Given this list of marker genes Ubc, Galnt15, Mrgprf, Snx25, Lgals1, Cfap161, Anks1b, Dok2, Lekr1, Sec61a2, Nadk2, Cfp, Podnl1 (NCBI Gene Id 546079), Il15, Birc6, Huwe1 (NCBI Gene Id 97602), Ercc2, Glipr1, Spata9, Stx2, Ttc27, Vps13c, Capn1, Camk2d, Tusc1, Pomgnt1, Cemip, Bnc2, Cd34, S100a4, Tlr12, Ctps2, Sybu, Smim38, Rgs16, Uba7, Zwilch, Cysrt1, Spn, Eef1b2 (NCBI Gene Id 80613), Masp1, Rgmb, Ints11, Cbl, Rps27l, Fbxw2, Tardbp, Klk10, Ube2t, Klhl22, Trmu, Ccr5, Snx17, Ptpn22, Hmgn1, Dock11, Dlgap2, Pih1d1, Cfap69 (NCBI Gene Id 207686), Cyfip1, Fyb2, Adgrg5, Adamtsl4, Sema3a, Ppp1r11, Thbd, Cd300lb, Apbb2, Prkcb, Slc39a12, Fn1, Spag5, Ahrr, Lgals3, Cabp4, Muc19, Pla2g4a, Axl, Cep89, Fah, Firrm, Lrp1, Fxyd5, Lst1, Gzmg, Glrx, Fam20a (NCBI Gene Id 208659), Itgbl1, Zfp740, Cd4, Gtf2h4, Nlrp3 (NCBI Gene Id 216799), Map1a, Calm3, Fastkd2, Pnck, Wnk1, Abca1, Mmp19, Il6st, Drg1, Fus, Dpep3, Ccnd1, Cdc7, Trpm2, Supv3l1, Mmp11, Elk4, Apobr, Strap, Vcl, Pdgfra, Kcnj10, Htr2a, Dennd4b, Uri1, Znrf1, Cyth4, Eps15, Lats2, Clec4n, Lancl3, Erap1, Nop56, Hddc3, Clip4, Vwa5a, Cryba4, Tfb2m (NCBI Gene Id 269153), Ech1, Plxdc1, Ndst3, Tnfrsf9, Zfp831, Upp1, H2-K1 (NCBI Gene Id 56628), Myo9b, Tep1, Fbxw10, Utp25, Eif4g2, Psme2, Rbms1, Emp3, Stard9, Prokr1, Lrrk2, Hspe1-rs1, Gmip, Anxa1, Pla2g2d, Nlrc3, Cast, Pilra (paired immunoglobin-like type 2 receptor alpha), Hoxc4, Pid1, Srsf3, Ran, Treml4, Rab7b, Fuz, Il1rl1, Dab2, Qrfp, Tnfrsf26, Nop14, Med12l, Pan3, Serp2, Nfkbiz, Anxa3, Pdlim2, Gfra2, Runx3, Nphp4, Armc6, Msln, Preb, Mtmr11, Timp1, Anxa2, Abcg3 (NCBI Gene Id 27405), Pcdh19, Ebf4, Lrrc41, Ttll3, Insl3, Vldlr, Mat2a, Txn2, Traf1, Tex26, Emp1, Myo9a, Dnajc24, Pvrig, Prss41, Plekha1, Vps13a, here is a description of the gene set: from publication Zeng Z, Gu SS, Wong CJ, Yang L, Ouardaoui N, Li D, Zhang W, Brown M, Liu XS (PMID 36240281) The top-ranked gene in metagene_3 was Lats2, a tumor suppressor gene, which has been shown to suppress Yes associated protein (YAP) activity and cell proliferation Mouse Gene Set: ZENG_GU_ICB_CONTROL_METAGENE_3_PRECICTIVE_ICB_RESPONSE studied in species Mus musculus Most patients with cancer are refractory to immune checkpoint blockade (ICB) therapy, and proper patient stratification remains an open question. Primary patient data suffer from high heterogeneity, low accessibility, and lack of proper controls. In contrast, syngeneic mouse tumor models enable controlled experiments with ICB treatments. Using transcriptomic and experimental variables from >700 ICB-treated/control syngeneic mouse tumors, developed a machine learning framework to model tumor immunity and identify factors influencing ICB response. Projected on human immunotherapy trial data, found that the model can predict clinical ICB response. further applied the model to predicting ICB-responsive/resistant cancer types in The Cancer Genome Atlas, which agreed well with existing clinical reports.